Given this list of marker genes CAPN9, LRBA, REG3A, H3-4, APRT, EPB41L4B, SLC22A4 (NCBI Gene Id 6583), F7, SYNGR2, RRH, FIGNL1, EFNA1, MRPL2, MAT1A, SCN1A, FAU, ITGA4, SPINT2, CRK, SEC11C, HPS1, RAMP3, SYNJ2BP, PAPSS2, PNKD, OR2S2, TOMM20, DAPK2, LDB1, VTN, PRR5, NEXMIF, CYP1A1, PHF7, CST9L, TYMS, GATA1, NAPB, FOXA2, EFNA2, KCNJ11, PTPN5, LTBP2, LEPROT, DNAH8, HLA-B, PCSK6 (proprotein convertase subtilisin/kexin type 6), RO60, PCID2, COL2A1, SPOUT1, NTSR1, ADCK1, CHCHD5, HOXD13, MYH1, FOSB, CLDN2, KLF10, ALDH7A1, SNRPB2, CHIC1, RTL6, GABRA3, UBC, ALDOB, MELTF, PDLIM4, PLAC1, IL7, VLDLR, MMP17, ATP9A, SERPINA10, MYBL2, SERPINB1, ELF3 (E74 like ETS transcription factor 3), PDGFRA, THUMPD1, CTNNBIP1, ZRSR2, IL12A, DNA2, PELI1, RHAG, ST3GAL2, MYO1B, PLA2G2C, EIF2B4, LCAT, ELOA, COL5A1, KRT7, PLBD1, CTSG, TBC1D24, COX4I1, IKBKE (inhibitor of nuclear factor kappa B kinase subunit epsilon), OR13J1, TEKT1, RNF123, RUFY1, HINFP, LSP1, BAAT, ZIC4, INTS14, FICD, TUBA4A, COL9A3, SHE, MX2 (MX dynamin like GTPase 2), ENPEP, ANKIB1, CHRNA6, CTDP1, MT4, GJB3, TRPC1, PTHLH, TAT, CPA3, C5, TXK, IL4, SLC44A4, DIAPH1, CACNA1B, DNAJA3, CD80, ANAPC1, CCNB1IP1, SGTA, ALX4, ACTR1B, KCNJ8, SHBG, CLN8, LAPTM4B, EPHA4, KRT15, C1QTNF1, NRCAM, SGO1, LMX1B, DEF8, UPP1, KCND2, PHF12 (PHD finger protein 12), KDELR2, CD4, MOV10, DTX1, C1R, ZYG11B, BEX4, CALML5, GNG3, IFT81, RBM25, SPCS2, SNW1, CCKBR, ZSCAN2, SLC35C2, F2RL2, AVPR1A, UBAP2L, FADD, CYP1A2, MMP7, KCNA2, ABCC8, HS3ST3A1, KRT27, KRR1, ACHE, CHAF1A, FAM83H, ZNF467, SEMA4B, GART, FOS, FAHD1, GNB3, CANX, RFC3, OPN1LW, FGF7, ANGPTL4, LUC7L2, HOMER1 (homer scaffold protein 1), FOXA3, PKN2, EXOSC5, TSKU, CASK, TBRG4, ACTG2, SLC6A18, here is a description of the gene set: Th17 cells are highly proinflammatory cells that are critical for clearing extracellular pathogens like fungal infections and for induction of multiple autoimmune diseases1. IL-23 plays a critical role in stabilizing and endowing Th17 cells with pathogenic effector functions2. Previous studies have shown that IL-23 signaling reinforces the Th17 phenotype by increasing expression of IL-23 receptor (IL-23R)3. However, the precise molecular mechanism by which IL-23 sustains the Th17 response and induces pathogenic effector functions has not been elucidated. Here, we used unbiased transcriptional profiling of developing Th17 cells to construct a model of their signaling network and identify major nodes that regulate Th17 development. We identified serum glucocorticoid kinase-1 (SGK1), as an essential node downstream of IL-23 signaling, critical for regulating IL-23R expression and for stabilizing the Th17 cell phenotype by deactivation of Foxo1, a direct repressor of IL-23R expression. A serine-threonine kinase homologous to AKT4, SGK1 has been associated with cell cycle and apoptosis, and has been shown to govern Na+ transport and homeostasis5, 6 7, 8. We here show that a modest increase in salt (NaCl) concentration induces SGK1 expression, promotes IL-23R expression and enhances Th17 cell differentiation in vitro and in vivo, ultimately accelerating the development of autoimmunity. The loss of SGK1 resulted in abrogation of Na+-mediated Th17 differentiation in an IL-23-dependent manner. These data indicate that SGK1 is a critical regulator for the induction of pathogenic Th17 cells and provides a molecular insight by which an environmental factor such as a high salt diet could trigger Th17 development and promote tissue inflammation. Genes up-regulated in CD4 T helper cells Th0: control versus NaCl treatment. from publication Wu C, Yosef N, Thalhamer T, Zhu C, Xiao S, Kishi Y, Regev A, Kuchroo VK (PMID 23467085) studied in species Homo sapiens Human Gene Set: GSE43957_UNTREATED_VS_NACL_TREATED_ANTI_CD3_CD28_STIM_CD4_TCELL_UP